Given this list of marker genes ELAPOR1, PMP2, CDH2, SPICE1, TXNL4B (thioredoxin like 4B), ZNF343, CRYGD, CMKLR1, CCDC121, TENM1, DSC2, PTHLH, SLC38A6, OPRM1, VSTM4, RND3, RPS6KA4, ACP5, SLC26A2, LINC02249, EHD3, CAMK4, INO80B, EDN2, RCN1, SLC12A3, ZNF155, RNFT2, GFI1B (growth factor independent 1B transcriptional repressor), KCNK10, ANKRD7, PKIA, EEF1A1 (eukaryotic translation elongation factor 1 alpha 1), SLC29A1 (solute carrier family 29 member 1 (Augustine blood group)), PPP2R5D, AKR1D1, DUS1L, TSPAN13, NCALD, TRAV12-2, ESM1, PTGDS, ADAM7, OAZ1, ENPP2 (NCBI Gene Id 5168), CDC20, LTA, NFYA (nuclear transcription factor Y subunit alpha), CEP131, ITK, MAP1A, UGCG, SPON1, LBP, DKKL1, CDKAL1, PRODH, GPRC5C, ZNF214, SPRYD7, TAOK2, RCOR3, MEOX2, POLR3B, MARCHF3, ZNF264, FBXO5, CES1P1, STARD8, ADCYAP1, TMSB15A (NCBI Gene Id 11013), TBR1, ERICH1, MAMLD1, SIT1, CCR10, COL3A1, PRR16 (NCBI Gene Id 51334), TCL1B, RS1, UGT2B4, KCNS3, CLEC11A, TOLLIP, KCNJ1, G6PC1, GALNT3, ABCD2, AOX1, CCL23, GAL3ST4, GABRP, TPP1, INO80D, GBE1, SIGLEC8, CDHR5, TSFM, GRIN1, ABCB1, PIP4K2B, NCLN, DENND2A, PTPRS (NCBI Gene Id 5802), AQP3, JCHAIN (NCBI Gene Id 3512), TFAP4, PLLP, ZNF37BP, FGF2, CENPM, KLF15 (KLF transcription factor 15), NECTIN2, GHR, TOGARAM1, UGT8, MBD5, SCARA3, IP6K1, CFHR5, AIRIM, SLC6A3, STC2 (NCBI Gene Id 8614), SLC7A11, MAL, LMO1, B2M, AFDN-DT, KIAA0040, DACT1, NEUROD6, DTX4 (deltex E3 ubiquitin ligase 4), RNF186, SENP2, SPTBN2, ATRNL1, GSDMD, MC1R (NCBI Gene Id 4157), KCND2, EPB41L4A, CUL5, LINC00216, CCR7, RUNX1T1, KLHL41 (kelch like family member 41), KCNA6, SCLY, FCMR, MAST4, PTTG1, SSR1, CCDC68, BCL2, ZNF239, CDK5R1, PDCD1, GP2, THAP7, EXT2, CA1, EGFR, IFT56, C19orf73, USP53, WNT7A, TUBB4A, SLC16A1, KANK1, WASF1, LYVE1, NRP1, ENTPD4, MTMR10, MAP3K9, CCNE2, TARBP2, ANKRD12, SMAD6, IGKC, CSF2, POLR1G, ASTN1, AMPD1, TCF4, KRT86, TMEM106C (transmembrane protein 106C), EGF, SYNPO, KIF4A, PHEX, CCL19, PTPN13, PLD1, ACKR2, SYBU, C1orf21, ZNF200, here is a description of the gene set: Human Gene Set: GSE29618_PRE_VS_DAY7_FLU_VACCINE_MDC_UP Genes up-regulated in comparison of plasmacytoid dendritic cells (DC) from influenza vaccinee at day 0 versus myeloid DCs at day 7 post-vaccination. species: Homo sapiens Systems vaccinology has emerged as an interdisciplinary field that combines systems wide measurements and network and predictive modeling applied to vaccinology. Here we used the systems vaccinology approach to study the molecular mechanisms underlying th from publication Nakaya HI, Wrammert J, Lee EK, Racioppi L, Marie-Kunze S, Haining WN, Means AR, Kasturi SP, Khan N, Li GM, McCausland M, Kanchan V, Kokko KE, Li S, Elbein R, Mehta AK, Aderem A, Subbarao K, Ahmed R, Pulendran B (PMID 21743478)